The following is a description of a gene set: Abnormal 3rd finger morphology species: Homo sapiens An anomaly of the third finger. Human Gene Set: HP_ABNORMAL_3RD_FINGER_MORPHOLOGY, and this is the list of marker genes: SMC1A, SLC26A2, NSDHL, MEG3, TBX2, COL1A1, FGFR2, IHH, CHSY1, GNAS, EN1, NEDD4L (NEDD4 like E3 ubiquitin protein ligase), RTL1 (retrotransposon Gag like 1), KNSTRN, TWIST1, PIK3CD, PKDCC (NCBI Gene Id 91461), MED25, COL2A1, GDF5, ERI1, TBX5, GLI3, DLK1 (NCBI Gene Id 8788), TBX3, PTRH2 (peptidyl-tRNA hydrolase 2), PLOD3